Given this list of marker genes Il13ra2, Cd300a, Lgals9, Nckap1l, Ceacam1, Spi1, Rabgef1, Bcr, Hmox1, Abr, Ccr2, Foxf1, Cd84, here is a description of the gene set: studied in species Mus musculus Mouse Gene Set: GOBP_NEGATIVE_REGULATION_OF_LEUKOCYTE_DEGRANULATION Any process that stops, prevents, or reduces the rate of leukocyte degranulation.